The following is a description of a gene set: Genes predicted to be targets of miRBase v22 microRNA mmu_miR_3083b_5p in miRDB v6.0 with MirTarget v4 prediction scores > 80 (high confidence targets). studied in species Mus musculus from publication Chen Y, Wang X (PMID 31504780) Mouse Gene Set: MIR_3083B_5P, and this is the list of marker genes: Tor1aip1, Upf2, Psd3, Syn3, Tpcn1, Castor2, Slc31a2, Cbx7, Klf3, Atad2b, Lypd6, Plekha2, Map2k3, Tbc1d24, Zfp775, Plec, Atg3, Adpgk, Lratd1, Frem2, Nfib, Slc66a3, Spred2, Cxcl16, Plekho2, Nkd1, Hdlbp, Hoxc5, Tmem266, Nrip3, Prr5l, Sys1, Snip1, Il17rd, Alox5ap, Unc5b, Slc29a3, Kprp, Nphs2, Rsad1, Mmp24, Nedd9, Ttyh3, Vcan, Rapgef2, Adcyap1r1, Efhd1, Fosl1, Pttg1ip (pituitary tumor-transforming 1 interacting protein), Pitpnm2, Dusp18, Rab8a, Rmi2, Nbea, Zfp704, Abi1, Hnrnph1, Slc25a22, Cgn, Znrf3, Msi2, Ppp1r9b, Tead1, Igdcc4, Septin6, Gbp8, Memo1, Nat8l, Mllt3, Mnt, Eef2k, Mcpt1, Srf